Given this list of marker genes Hmox1, Fga, Faim, Icam1, Atf3, Tnfrsf23, Sfrp1, Rnf34, Stk4, D1Pas1, Sp100, Trps1, Sfrp2, Skil, Gpx1, Rffl, Fgb, Gsk3b, Tmbim1, Tnfrsf22, Tmc8 (NCBI Gene Id 276788), Faim2, Stx4a, Park7, Fgg, Stk3, Thbs1, Faf1, Zswim2, Brca1, Mal, Cflar, Ddx3x, Raf1, Pmaip1, Hmgb2, Grina, Lgals3, Fem1b, Nol3, Itprip, Bcl2l1, Faiml, Bmpr1b, Serpine1, Tnfaip3, Psen2, Pea15a, Madd, Hgf, here is a description of the gene set: Any process that modulates the frequency, rate or extent of extrinsic apoptotic signaling pathway via death domain receptors. Mouse Gene Set: GOBP_REGULATION_OF_EXTRINSIC_APOPTOTIC_SIGNALING_PATHWAY_VIA_DEATH_DOMAIN_RECEPTORS studied in species Mus musculus